The following is a description of a gene set: Human Gene Set: HP_ABNORMALITY_OF_COMPLEMENT_SYSTEM An abnormality of the complement system. species: Homo sapiens Abnormality of complement system, and this is the list of marker genes: CFHR1, C1S, TNFSF4, LMNB2, DNASE1, CFI, MECP2, JAZF1 (NCBI Gene Id 94314), CFB, C3, TLR7, C8B, FCGR2B, PXK, SPP1, SAT1, TREX1, CTLA4, PACS1, C8A, C7, C5, C1QC, GALK1, C4B, DNASE1L3, TNFAIP3, SLC7A7, SERPING1, C1QA, CR2, C6, CFP (NCBI Gene Id 5200), BLK, PDCD1, IGHG1, IL10, CFD, ITGAM, ETS1, C9 (NCBI Gene Id 12279), PLCG1, MASP2, STAT4, HLA-DRB1, CFHR3, IRF5, PTPN22, C4A, BANK1, LMNA, TNIP1, KIAA0319L, UBE2L3, IRAK1, FCGR3B, C1QB, PRKCD (protein kinase C delta), THBD, CD46, CFH